Given this list of marker genes Dll1, Wnt5a, Mib1, Asb2, Srf, Ihh, Arl13b, Tead1, Mef2c, Dvl2, Smad3, Foxn4, Tgfbr2, Rbpj, Megf8, Ryr2, Tbx3, Zic3, Kif3a (kinesin family member 3A), Smo, Tead2, Acvr1, Nodal, Gata4, Wnt3a, Notch2, Hand2 (heart and neural crest derivatives expressed 2), Ift57, Sufu, Ift52, Notch1, Tmed2, Fgf8, Tbx2, Dnaaf1, Shh, Sox17, Kdm2a, Rnf207, Hes1, Setdb2, Ccdc40, Vangl2, Eng, Cluap1, Yap1, Cited2, Nkx2-5, Ccdc103 (NCBI Gene Id 73293), Mical2, Lrp6, Hif1a, Mesp1, Lbx1, Ift172, Cfc1, Ovol2, Noto, Foxh1, Folr1, Psen1, Tbx20, C2cd3, Nphp3, Pkd2, Ccdc39, Stil, Hand1, Gja1, Aldh1a2, Dvl1, Aplnr, here is a description of the gene set: The process in which the anatomical structures of the embryonic heart tube are generated and organized. The embryonic heart tube is an epithelial tube that will give rise to the mature heart. Mouse Gene Set: GOBP_EMBRYONIC_HEART_TUBE_MORPHOGENESIS studied in species Mus musculus